Given this list of marker genes Ippk, Ip6k2, Ipmk, here is a description of the gene set: electronically inferred by orthology from the curated human pathway Reactome Pathway: Synthesis of IPs in the nucleus part of: Inositol phosphate metabolism This event has been computationally inferred from an event that has been demonstrated in another species.<p>The inference is based on the homology mapping from PANTHER. Briefly, reactions for which all involved PhysicalEntities (in input, output and catalyst) have a mapped orthologue/paralogue (for complexes at least 75% of components must have a mapping) are inferred to the other species. species: Mus musculus